Given this list of marker genes CFL1, CCND1, NXT1, E2F1, PRB1, CDKN1B, ARF3 (ADP ribosylation factor 3), MDM2 (MDM2 proto-oncogene), E2F2, TP53, CDKN1A, CDK4, CDK2, CDKN2A, ARF1, here is a description of the gene set: Cdk2, 4, and 6 bind cyclin D in G1, while cdk2/cyclin E promotes the G1/S transition. species: Homo sapiens Human Gene Set: SA_G1_AND_S_PHASES